Given this list of marker genes UCP2, POR, GBA1, CRH, TGFB1, HDAC3, ASS1, EIF4E, SMYD3, PCK1, SRD5A1, CBX3, CPS1, ATP5F1A, ABCB1, AQP1, TBX2, SERPINF1, JAK2, FECH, ERRFI1, METTL21C, BMI1, EDN1, AXIN2, CFLAR, CASP9, PCK2, USP8, TAT, NR3C1, PCNA, PIK3CA, EPO, DDIT4, TFAP4, FBXO32, CLDN1, HDAC6, MSTN, FOXO3, RPS6KB1, CEBPA, GHSR, here is a description of the gene set: Human Gene Set: GOBP_RESPONSE_TO_DEXAMETHASONE Any process that results in a change in state or activity of a cell or an organism (in terms of movement, secretion, enzyme production, gene expression, etc.) as a result of a dexamethasone stimulus. studied in species Homo sapiens